Given this list of marker genes CHAT, PDHA1, PCYT1A, CHKA, PEMT, PDHA2, ACHE, here is a description of the gene set: Acetylcholine synthesis Human Gene Set: WP_ACETYLCHOLINE_SYNTHESIS species: Homo sapiens